Given this list of marker genes Akr1c18, Dkk3, Nfkb1, Bmp5, Atp1a1 (NCBI Gene Id 229653), Wnt4, Rest (RE1-silencing transcription factor), Cacna1a, Gfi1, Cyp27b1 (NCBI Gene Id 216437), Bmp2, Prmt3, Pde8b, here is a description of the gene set: species: Mus musculus Mouse Gene Set: GOBP_NEGATIVE_REGULATION_OF_HORMONE_METABOLIC_PROCESS Any process that stops, prevents, or reduces the frequency, rate or extent of the chemical reactions and pathways involving any hormone.